The following is a description of a gene set: Energy pathways and carbohydrate metabolism. studied in species Homo sapiens Human Gene Set: MODULE_377, and this is the list of marker genes: GGTLC1, ENO2, LDHA, ENO1, HK2, ADH4, NAT1, NAT2, GLYAT, ALAS1 (NCBI Gene Id 211), GGT1